Given this list of marker genes 1700025G04Rik, Creg1, Slc16a6, Pcdhga6, Dock5, Zc3h12d, Tktl2, Cd4, D430019H16Rik, Egr3, Hrh1, Ptgdr, Lrtm2, Hacl1, Rp1, L1cam, 2210418O10Rik, Clec2l, Snrpn, Ttll1, Ikzf3, Dapp1, Kcnv2, Arpp21, Zfp449, Nfat5, Dph6, Frmd5, Scd3, Skil, Gm14326, Cask, Map7d1, Plxdc2, Hook3, Cdh2, Epha7, Mllt3, Oprm1, Kdm6b, Tcte1, Sgk3, Pcdhga5, Slc16a5, Ric8b, Nxpe3, Porcn (porcupine O-acyltransferase), Gdpgp1, Eef2k, Pde10a, Sla, Senp1, Znrf3, Mr1, Apba1, Rnf220, Atp2b2, Ccdc115, Tpgs2, Edaradd, Nkain2, Sytl5, E2f8, Elp4 (NCBI Gene Id 77766), Ccdc3, Zmiz1, Dtx3l, Prss42, Triobp, Usf3, Gas2l1, Olig2, Pard3b, Wscd1, Cd84, Asb13, Gfra2, Vti1a, Pou2f2, Fgf14, Fbxo31, Cxcl15, Srpx2, Ttf1, Zfp799, Igf2, Dmrta1, Rara, Rasal2, Kank2, Slc7a8, Pth2r, St8sia3, Tyw3, Camta1, Csnk2a2, Ulk1, Dcbld2, Sri, Slc6a17, Sptlc3, Ttc4, Tcp11l1, Zfp606, Nrxn3, Sox1, Zfhx3, Elmod2, Myorg (NCBI Gene Id 99968), Rnasel, Map3k7, Pou4f2, Mex3a, Krt222, Gjc3 (gap junction protein, gamma 3), Map3k20, Pcdhgb8, Kcna2, Lin7a, Sema6a, Doc2b, Ranbp3l, Itgam, Gpr173, Pcdhb7, Jarid2, Ifi44, Gcm2, Mtmr12, Klhl34, Idua, Ubfd1, Ptchd1, Urb2, Prss23, Erg, Galntl6, Tmem221, Rgr, Dhdh, Slmap, Gria3, Kif1a, Enpp1, Smo, Xylb, Prlr, Fsd1l, Tamalin, Bmp4, Zfp764, Pcdhga3, Rnf170, Vps37a, Celf4, Rspo1, Rfk, Zfp46, Zdhhc21, Lsm1, Slc38a6, Sowahc, Enpp6, Mlxip, Barhl2, Slc1a2, Itga11, Igsf6 (NCBI Gene Id 80719), Tti1, Podn, Cacna1c, Asap3 (NCBI Gene Id 230837), Sdf4, Ugcg, Oacyl (NCBI Gene Id 319888), Syt15, Alppl2, Plcb1, Slc22a8, Zfp148, Tmem236, Opcml, Siah2, Cbln3, Grk3, Pcdhgb7, Ubqln2 (ubiquilin 2), Cds2, Ccpg1, Chd7, Stat6, Sarm1, Trip12, Pcdha4b, Uncx, Pof1b, Arhgef17, Abce1, Cdh7, Snx12, Mtus2, Nmrk1, Tmem150c, Runx1, Tgfb2, Amotl1, Il18r1, Golm2, Stk32a (serine/threonine kinase 32A), Tmem104, Acp1, Nkap, Nalf1, Elfn2, Onecut2, Cend1, Pgap1, Igf2bp2, Lyz3, Lsm14a, Bnc2, Dse, Prpf4, Sptlc2, Cntn3, Ufm1, Gnaz, Zfp37, Mcidas, Cnga2, Zbtb7b, Evx2, Aoc1, Thada, Rhobtb1, Atf2, Mlec, Vps33b, Psd3, Frk, Pank1, Arl13b, Ssr1, Prkci, Klhl23, Hoxa5, Nat8f2, Tmem47, Prr11, Stard8, Pcmtd1, Fmn2, Nrbp2, Rab7, Gpr45, Arid4b (NCBI Gene Id 94246), S2bpcox16, Urod, Ddx19b, Mab21l2, Pcdhga9, Dtna, Cplx2, Katnal1, Pcdhga8, Srsf12, Unc13b, Rab11fip1, 1110059E24Rik, Cox15, Rora (NCBI Gene Id 319897), Sgk1, Srf, Slc5a12, Zscan29, Lhfpl3, Eogt, Fam169b, Atg10, Arih1 (NCBI Gene Id 23806), Rpp25, Pcdhga2, Eif2b3, Glis3, Mrpl19, Ctse, Cxcl12, Reps2, Tmem196, Rims2, Acp3, Zyg11b, Tmem141, Ptgfr, Synj2bp, Gtf2h2, Cdh12, Garre1, Brix1, Dhh, Nab2, Cyth3, Gm4841, Micall1, Iigp1, Zfp747, Adhfe1, Pcdhgb5, Cradd, Zfp663, Lcorl, Bdh1, Steap2, Cldn34c1, Wipf2, Lhx6, Tigar, Ackr4, Exoc4, Prelid3a, Vezt, Zfp655, Kmt5b, Igf1r, Zfp516, Ewsr1, Napb, Lpar2, Bmp3, Clvs1, Sox7, D630045J12Rik, Setd7, Fech, P4ha3, Gabrb3, Acvr2b, Trmt2b, Ebf3, Slc7a1, Mapk11, Sin3a, Iglon5, Ubtf, Timm21, Tead1, Parp3, Kcnj16, Pgm5, Zfp696 (NCBI Gene Id 319792), Camk2n1, Pirt, Tns1, D630003M21Rik, B3galt6, Creg2, Iars2, Shisa6, Scn8a, Slc4a4, Dnajc19, Muc13, Pcdhgc5, Zfp92, Timm8a2, Plppr1, Cntn2, Lrrc39 (leucine rich repeat containing 39), Syn3, Sv2b, Dcdc2c, Aldh5a1, Gpr68, Ms4a4c, Macroh2a2, Aptx, Ap1ar, Igfbp3, Zfp248, Nid1, Vwa5b2, Slc17a5, Zfp936, Ifnlr1, Draxin, Plac9, Tnr, Tmtc3, Vangl1, Tmco1, Lrrn4cl, Septin3, Havcr2, Bgn, Efna5, Egfl6, Acss1, Papss2, Plpbp, Deup1, Psg26, Tmem151b, Bmpr2, Tacr1, Pappa2, Sema5a, Dnase1l3, Tbc1d30, Npr3, Atp9b, Rpusd2, Cpne8, Cnksr2 (NCBI Gene Id 245684), Napepld, Mapk8, Xk, Zfp334, Rgs4 (regulator of G-protein signaling 4), Zfx, St18, Lbp, Mapkbp1, Dhfr, Marf1, Med14, Slc10a2 (solute carrier family 10, member 2), Gm14137 (NCBI Gene Id 639597), Nos1, Btbd8, Sp100, Lcp2, Slc8a3, Fam32a, Pcdhga4, Ascl1, Muc4, Lrrc32, Zfp446, Tnrc6c, Rfx3, Mapk6, Ehhadh, Lrp2bp, Rad18, Arhgef9, Meis2, Fgf23, Mfsd6, Gm6710, Cfap97, Slc30a10, Wiz, Fyco1, Rab3c, Sfrp1, Zfp329, Gna13, Neurod2, Foxn1, Prrc2b, Cachd1 (cache domain containing 1), Mrpl17, Slc16a7, Rasa2, Cdh6, Trim33, Unc5d, Fblim1, Slc22a15, Angpt2, Itih5, Stxbp5l, Zeb2, Col13a1, Grm1, Chrnd, Nrip3, Dcx, Cdc42ep4, Prex2, B3gnt9, Maf, Wrn, Pigh, Fat3, Osr1, Abcc9, Setd3, Casp8, Rslcan18, Nwd1 (NCBI Gene Id 319555), Kcnb1, Mrgpre, Pafah1b1, Hspb7, Vsnl1, Anks1b, Insr, Kcnj15, Kmt5a, Pstpip2, Gabbr1, Cnih3, Snurf, 4921509C19Rik, Bcl2l11, Pcdhgb2, Sh3bgrl2, Zbtb4, Pitpnb, Cd300ld, Gadl1, Zfp488, Sh2d2a, Ctsc, Pogk, Fam174b, Nedd4l, Liph, Adcyap1, Mapk10, Proser3, Asxl2, Sim1 (NCBI Gene Id 268299), Dnaaf5 (NCBI Gene Id 97207), Fam107a, Paics, Cd160, Pfkfb2, Nfasc, Galnt13, Cap2, Bend3 (NCBI Gene Id 331623), Ift57, Lrat, Gnal, Lbr, Camk2a, Slc31a2, Tmod2, Chst2, Slc25a12 (NCBI Gene Id 99450), Vapb, Oxtr, Gm4724, Adam12, Cyp2s1, Dnlz, Brwd3, Raph1, Ppfia2, Ints10, Kcnq2, Serinc3, Tent5a, Cgas, Izumo3, Cmah, Fbxo43, Pate9, Sp9, Slc6a6, Pcdhga11, Sh3rf3, Bin2, Poc1b, Zfp691, Pik3r5, Ano3, Pcdh10, Cnot7, Pcdh17 (protocadherin 17), Cxcr6, Tenm2, Irf2bp2, Rgs5, Zrsr2, Fam169a, Kcnmb1, Rassf2, Cdk5r1 (cyclin dependent kinase 5, regulatory subunit 1), Slc24a2, Gm38666, Wdr46, Oas1g, Zfp811, Trpc5, Homer2, Usp25, Neu1, Csf2ra, Iars1, Snap25, Rgs17, Mon1b, Trpc7, Scn3b (NCBI Gene Id 71632), Mbnl3, Itga9, Smyd3, Alox8, Fcrl6, Rnf150, Cd27, Vangl2, Knstrn, Zfp827, Vamp5, Foxn3, D630023F18Rik (RIKEN cDNA D630023F18 gene), Pcdhgc3, Ascl4, Camk1d, Stk10, Dcaf1, Pdzrn3, Zfp831, Chrnb4, Aldh8a1, Dppa1, Ms4a5, Gas2l3, Zfp91, Prr12, Mbtps2, Aak1, Adgrf5, Car10, Kcnj1, Elavl3, Mettl21e, B4galt6, Nat8l, Sowahb, Mbtd1, Zfand2a, Foxp1, Mettl27, Sema5b, Pcdhgb1, Katnip, Slc5a8, Atrn, Oxsm, Gm14308, Trpc6, Snap23, Onecut3, Ccdc38, Kat6a, Phactr3, Ugt2b34, Dcdc2a, Nmnat2 (nicotinamide nucleotide adenylyltransferase 2), Hoxc8, Fbxl17, Ado, Efcab14 (NCBI Gene Id 230648), Fermt1, Harbi1, Rdh12, Bmp7, Arhgap25, Cdh5, Septin6, Gabrq, Ncam2, Prkcb, Atxn1, Flnb, Ccdc71l, Pcdhgb4, Mobp, Ttc12 (tetratricopeptide repeat domain 12), Rab6b, Magee2, Pxk, Rabgap1, Cdh20, Tfap2b, Nufip1, Rorb (NCBI Gene Id 225998), Tph1, Elovl6, AI429214, Prkcd, Tafa3, Trp53i11, Zfp74, Ngfr, Metrnl, Ildr2, Vipr2, Pcdhga12 (protocadherin gamma subfamily A, 12), Kcnip3, Dctd, Xrcc3, Cdk13, Plp1, Srgap3, Tnfrsf11a, Cd99l2, Kcnk10, Thsd7a, Adgra1, Maml3, Cox10, Trpm3, Slco3a1, Kcng3, Cacna2d2, Tbx15, Fbxw5, Lnpk, Gabrb2, Msrb3, Kcnc1, Runx1t1, Man1c1, Gcnt4, Ncan, B230217C12Rik, Wnk1, Pcdhga1, Bicd1, Pou3f2, Gask1a, Mospd1, Asah2, Nrp2, Cd33, Gls, Ppp1r16b, Mafb, Nqo2, Tbc1d1, Pter (NCBI Gene Id 99072), Nsun3, Rfx7 (regulatory factor X, 7), Rhou (ras homolog family member U), Thsd4, Cyp2c65, Peli2, Man2a2, Meltf, Zfp641, Trub2, Ptpre, Klf6, Acot3, Gng2, Chmp1b2, Ssbp4, Psd2, Nhsl1, Marchf4, Rusf1, Ctdsp2, Ncam1, Prxl2a, Alox5, Bcl2, Tmem52b, Htt, Prps1l1, Grik3, Pacsin2, Shroom3, Bcor, Ptprb, Gm14325, Unc93a, Irag1, Chic2, Pld5, Rit2, Ccdc85a, H2bc6, Lrrc61, Mdm2, Il22ra1, Nmrk2, Lnx2, Ndufaf4, Ddi2, Elovl5, Akap13, Hexim2, Rgs9bp, Mul1, Gm14391, Cpm, Prdm8, Insyn2a (inhibitory synaptic factor 2A), Atp2b3, Itsn1, Nr4a2, Acot2, Fig4, Runx3, Mpg, Nab1, Nkx2-9, Cd274, Tafa1, Zfp39, Wipf3, Faf2, Mymk, Tnfrsf13c, Tgfa, Pdcd4, Pgbd1, Sike1, Nrxn1, Ilrun, Gm14151, Rimkla, Prr5l, Nfya, Rmi1, Zfp239, Smarca2, Ceacam2, Cp, Rab9b, Cyyr1, Samd7, Tmem26, Cer1, C5ar2, Wnt4, Ncoa2, Gpr179, Pdik1l, Pign, Ccna2, Coq8a, Nagpa, U2surp, Atp11a, Adamts14, Iqgap2, Pclo (piccolo (presynaptic cytomatrix protein)), Tacc1, Acot4, Smpd4, Fgf12, Ppp1r1c, Mup18, Pcdhga10, Enc1, Ankrd17, Kcna7, Pcdhgc4, Elp1, Fgf11, Pura, Xpr1, Hpca, Fezf1, Ceacam1, Ostm1, Ddo, Dkk1, Ank2, Foxj1, Prokr2, Ajap1, Saa4, Wars2, Lpp, Sh3bp5, Acsm2, Aldh1l2, Nlgn3, Fbxw28, Oas1a, Tet2 (tet methylcytosine dioxygenase 2), Epas1, Fndc3a, Sowaha, Prdm12, Cyb5r3, Mta3, Bnip2, Pcdhgb6, Slco2a1, Far2 (NCBI Gene Id 330450), Thbs2, Extl3, Pou3f4 (POU domain, class 3, transcription factor 4), Prkx, Ap3s2, Slc39a14, Deptor, Calcoco1, Actr1b, Foxa1, Lyrm9, Baz2b, Chst3, Shisal1, Epha4, Greb1, Stk35, Dgkg (NCBI Gene Id 73000), Has2, Supt7l, B4galnt2, Accs, Col19a1, Ly6g6c, Adarb2, Kirrel3 (NCBI Gene Id 72851), Ago3, Kcnh1, Acsl4, Ehd3, Dmd, St8sia1, Lgals12, Ap1g1, Fbrs, Treml2, Dusp7 (NCBI Gene Id 235584), Peg3 (paternally expressed 3), Cd7, Iffo2, Ski, Atm, Riok3, H2-M2, Pilra, Elfn1, Zfp607b, Ogdh, Chst11, Zfp365, Cstad, Vegfb, Nphp3, Mecp2, Rab2b, Tacr2, Naip6, Tns4, Tc2n, Slc8a1, Adra1b, Gatc, Nr3c2, Ipcef1, Ralgapa2, Ubap2l, Zfp712 (zinc finger protein 712), Ece1, Stxbp4, Rsph4a, Zfyve16, Prkcg, Snai2, Trim67, Coq5, Cdk6, Fam149b, Rab9, Tubb4a, Sox5, Gm14434, Cd2ap, Cyp4a31, Terf2ip (telomeric repeat binding factor 2, interacting protein), Yipf6, Arhgdib, Pfn1 (NCBI Gene Id 18643), Glra2, Slc25a21, Cox16, Cd28, Trim65, Zfand5, Zfp318 (NCBI Gene Id 78588), Adamts17, Creb3l1, Ppp1r9a, Myo5a, Sparc, Mfap3l, Rnf44, Uck2, 3425401B19Rik, Pcdhga7, Tub (TUB bipartite transcription factor), Igsf11, Sdr42e1, Cat, Flrt1, Slc35e2, Kif3a, Pakap, Htra4, Mocs1 (NCBI Gene Id 73195), Ttc39b, Lyplal1 (NCBI Gene Id 226791), Ceacam18, Jmjd8, Zfp763, Foxk1 (NCBI Gene Id 17425), Grid1, F10 (NCBI Gene Id 14058), Nhp2, here is a description of the gene set: studied in species Mus musculus Mouse Gene Set: MIR_466L_5P from publication Chen Y, Wang X (PMID 31504780) Genes predicted to be targets of miRBase v22 microRNA mmu_miR_466l_5p in miRDB v6.0 with MirTarget v4 prediction scores > 80 (high confidence targets).